The following is a description of a gene set: studied in species Mus musculus Binding to phosphatidylglycerol. Mouse Gene Set: GOMF_PHOSPHATIDYLGLYCEROL_BINDING, and this is the list of marker genes: Stoml2, Mme, Gsdme, Uqcc3, Rpe65, Irgm1, Pitpnc1, Opa1, Ckmt2, Atp8b1, Gsdma3, Nme4, Spata18, Igtp, Pltp, Ucp1, Gsdmd, Irgm2, Anxa13, Plekhn1